Given this list of marker genes SNCA, STX1B, SV2A, BRSK1, NAPA, UNC13A, EFR3A (EFR3 homolog A), SYNGR3, RIMS3, SYP, STXBP5, CADPS2, RIMS1, UNC13C, UNC13B, SNAP25, STXBP1, RPH3A, STX1A (NCBI Gene Id 6804), SYNJ1, RIMS2, SNAP29, SNAP47, SNAP23, ERC2, OSBPL2, NAPB, here is a description of the gene set: species: Homo sapiens Human Gene Set: GOBP_SYNAPTIC_VESICLE_PRIMING A process that converts synaptic vesicles to a state of competence for calcium triggered fusion with the active zone membrane by bringing the two membranes into very close proximity. Priming typically (but not always) occurs after docking. Primed vesicles are also capable of spontaneously fusing with the active zone membrane.